Given this list of marker genes Akr7a5, Ushbp1 (NCBI Gene Id 75670), Arhgap27os1, Rps6-ps3, Itpr2, Babam2, Zbtb25, Gm14098, Gm18859, Crybg2, Gm4847, Haus5, H2-M5, S100pbp, Gtf2ird1, Terf2, Zdhhc5, Tigd4, Shoc1, Esyt2, Gm12620, Gm11949, Tifab, C230066G23Rik, Gnai2, Sass6, Snta1, Dnajc11, Nfasc, Cradd, Xpnpep2, Mrpl21, Pcdhgc5, Pou2f2, Timm17b, Gm15779, Sinhcaf, Gm15610, Gamt, Kcnh8, Dennd2a, Gm9506, Doc2g, Gm2431, Cnppd1, Atp5f1d, Gm14175, Sdf2, Btrc, Defb23, Golga5, Bnc1, Hmgb1-rs16, Gpr62, Tpd52l2 (tumor protein D52-like 2), Efna3, 2410002F23Rik, Prickle4, 9530068E07Rik, Kdm5c (NCBI Gene Id 399585), Sgip1, Fbxo36, Gm11662 (NCBI Gene Id 666739), Cep95, Zbtb1, Srrm4, Capza1, Idh2, Pik3ap1, Ptbp1, Gm15446, Hspa8, A430072P03Rik, Rps12-ps7, Zfp809, Hkdc1, Trpm1, Grin3b (NCBI Gene Id 170483), Habp2, C130036L24Rik, Rnf2, Gapdh, Mrpl14, Plekhg1, Il17rd, Dsc1, Rora, Btbd19, Gm27811, Gm8849, Ccdc116, Agap3, Trav6-3, Dhx16, Gm36536, AA465934, Klf1, Gsr, Slc2a9, Surf6, Hsp90ab1, Cyp4a28-ps (cytochrome P450, family 4, subfamily a, polypeptide 28, pseudogene), Kntc1, Cd9, Ighg1, Magohb, Gm26247, Arpp21, Was, Gc, Zwilch, Amz1, Gm28836, Tulp1 (TUB like protein 1), Ube2i, Atrip, 2810407A14Rik, Map4, Babam1, Sbno1, Scin, Eva1c, Ube2c, Gm8398, Scn9a, Sf3a3, Hspd1-ps3, Caml, Fkbp7, P2rx7, 4930528J11Rik, Ninj2, Yars1, Faddos, Klf13, Exosc2, Capn10, Bace1, Uba52, Gm24888, Lingo4, Tex14, Gm12980, Ccdc14, Mir7668, Xab2, Pkd2l1, Rabl6, Pik3r1, Rpl26, Gm26070, Pisd-ps1, Gm24296, Park7, Ckap2, Dhx9, Gm15821, Nbeal2, Gcc1, Bscl2, Gm14901, Ino80d, Gltpd2, Adarb1, Gm12936, Fam186b, Gm7993, Cdh13, Map2k1, Pde9a, Tatdn2, Gsdma2, Mdk, Fxr2, Abhd16a, Syne4, Tbx3os1, Tmem199, Il27ra, Gm9887, Rpl38, Abtb3, Kit, Tnfrsf1a, Trp53i13, Ppp2r5c, Ing3, Mis18bp1, Tmc2, Tspan17, Usp14, Ywhag, Gm12608, Nr6a1os, Lbhd1, Gm9097, Lag3, Jakmip1, Gm22122, B3gnt2, Bola2, Rfx2, Elavl2, Nectin3 (nectin cell adhesion molecule 3), Kcnt2, Saraf, Nme4, Gm26885, Tex10, Zfp27, Slc2a3, Tet3, Fcgr3, Tdrd9, Gm25369, Lcn12, Rbm5, Rfwd3, Islr, Glo1-ps, Mcm2, 2900079G21Rik (RIKEN cDNA 2900079G21 gene), Togaram2, Rad51c, Tenm4, A630072M18Rik, Gm34248, Gm7094, Trap1, Dnajb2, Gapdhrt, Lrrc23, Gm8213, Gm9359, Ercc6, 4933434E20Rik, Sec16a, Cp, Rsrc2, Spock2 (sparc/osteonectin, cwcv and kazal-like domains proteoglycan 2), Zbtb8a, Ppp1r8, Metap2, Eif2d, Chrna9, Ccdc65, Ppard, Frmd5, Banp, Ddb2, Tmem242, Gm12740, Eif1ad8 (eukaryotic translation initiation factor 1A domain containing 8), Gm28874, Misp, Rex1bd, 5430401F13Rik, Rpsa-ps9, Smg7, Mdfic2, Chchd2-ps, 4930533L02Rik, Vac14, Gpr35, Unc119b, Eif2ak4, Gm25184, Srsf1, Mtus2, Zfat, Elp5, Gm19261, Gm4349, Eif5a, Cbfb, Setd1a, Mbtps2, Tsc22d4, Tpd52, Pla2g10, Gm10073, Gm23054, Atxn3, Klhl18, Gm12654, Nos1 (nitric oxide synthase 1, neuronal), Mir376c, Lyl1, Gfi1, Fam98c, Smc3, Ino80dos, Rpl10, Myo15a, Gm9599, Lrrc42, Gm16580, Jak1, Poc1a, Znrf1, Sirt7, Strn4, Gm3985, Tmem53, Csf1r, 1700008O03Rik, Gm24461, Gm25482, Cyp2b23, Hspa4, Gm6285, Fbxw27, Hoxa7, 5031434O11Rik, Mfsd11, Ankrd60, Myo1g, here is a description of the gene set: from publication Yevshin I, Sharipov R, Kolmykov S, Kondrakhin Y, Kolpakov F (PMID 30445619) Mouse Gene Set: GM14326_TARGET_GENES studied in species Mus musculus